Given this list of marker genes EZH2, HRAS, ERI1, ZFX, NSD1, SUZ12, here is a description of the gene set: Human Gene Set: HP_DEEP_SET_NAILS studied in species Homo sapiens Deeply placed nails. Deep-set nails